Given this list of marker genes HTR2C (NCBI Gene Id 3358), SYT14, ARK2N, INPP5F (NCBI Gene Id 22876), DOCK5, POLR1D, SPATS2L, SRSF11, STXBP5, ENSA, PLXNA4, QKI, TRIP12, HOXB2, TCTN1, RNF4, HIRA, APPL1, CXXC4, TXNRD1, CCDC6, MYD88, ZNF148, IDO1, HDGF, MAP3K2, KIF26B, RAPGEF4, FAM199X, PRKAR2B, HEBP1 (NCBI Gene Id 50865), SAV1, MOB1B, MROH2A, ZFP62, CTTN, SCN4B, CPD, MED1, RFC3, SNTB1, SEC62, ZNF575, POGZ, PPM1A, ANGPTL7, ZNF226, OSBPL10, EDIL3, ZNF816-ZNF321P, CREBRF, SPRING1, TBL1XR1, METTL9, SLC25A40, ZNF629, ZBTB20, ZNF114, FOXJ3, DCLK1, FN1, TMEM92, USP15, TMEM51, VIT, IFIT1, FAM228A, ZC3H11A, TAPBPL, SEC24A, PIGK, SENP1, ZNF334, PRKACB, PARP16, SLC25A21, METAP2, ATP1A1, VGLL4, SERTAD2, RNF32, SARAF, SLC27A2, SCCPDH, GOLM1, KANSL1L, INA, SP4, USP45, AHRR, SLITRK4, ULK2, PABIR3, OXR1, PIP4K2A, ZNF852, NFAT5, RERE, TENM1, DYNC1I2 (dynein cytoplasmic 1 intermediate chain 2), NSD2, CRLS1, ZBTB1, SNAP29, BACE1, OPRM1, YWHAQ, MACIR, ACSL3, BAZ1A, DEFB118, ANKRD46, CRYZ, SYPL1, LCMT2, SMC5, ZNF432, MRPL19, ERCC4, ENPP4, PHLDA1, PEX5, KPNA4 (karyopherin subunit alpha 4), DENND1B (NCBI Gene Id 54530), CYBRD1, MEX3B, RC3H1, S1PR5, SESN3, CEP350, KBTBD11, SLC25A3, POU2AF3, UNK, SCLY, JRKL, PLD5, ZFAND5, KCTD1, SORBS1, RFX7, TCEAL4, F3, TTC29, TIMP3, RBBP7, KLHDC10, BNC1, TSHZ1, IGF1, EAF1, CREG2, ODF1, SH3TC2, SNX18, ADARB1, DARS2, PORCN, HNRNPK, CCN2, SLC30A4, PRDM16, CCDC140, APOOL, NEK6, EBF2, FGD6, PGAP1, ZFP14, GPBP1, GNAI3, CDC14B, TET2, GRID2, ASAP2, NOG, AFAP1L2, NFATC3, CAPS2, ATP6V1D, MRE11, SERF2, PICALM, BACH2, VCF2, here is a description of the gene set: Human Gene Set: MIR3685 from publication Chen Y, Wang X (PMID 31504780) Genes predicted to be targets of miRBase v22 microRNA hsa-miR-3685 in miRDB v6.0 with MirTarget v4 prediction scores > 80 (high confidence targets). studied in species Homo sapiens